The following is a description of a gene set: Mouse Gene Set: GOBP_POSITIVE_REGULATION_OF_RAC_PROTEIN_SIGNAL_TRANSDUCTION Any process that activates or increases the frequency, rate or extent of Rac protein signal transduction. species: Mus musculus, and this is the list of marker genes: Dynlt1b (NCBI Gene Id 21648), Dynlt1f, Dynlt1c, Pik3cg, Agrn, Rtn4, Musk, Dynlt1a, Dock2, Dok7, Lrp4, Camk2d, Crk, Crkl, Tns3, Kras, Auts2, Pik3cb, Fnta (NCBI Gene Id 14272)